Given this list of marker genes SNUPN, MAPT, GMPPB, MORC2, NOTCH2NLC, ABCD1, GNE, RILPL1, FKTN, COL13A1, AIFM1, MPZ, HARS1, SCYL1, SLC12A6, VWA1 (NCBI Gene Id 64856), AGRN, GDAP1, WARS1, DNM2, SLC5A6, IBA57, BSCL2 (BSCL2 lipid droplet biogenesis associated, seipin), HSPB8, DDHD2, VCP, EXTL3, PNPLA6, MT-ATP6, HINT1, SECISBP2, PMP22, SPG11, TRPV4, SPTLC2, VAMP1, GNB4, MATR3, TTN, PMP2, CHCHD10, JAG2, SARDH, MME, GYG1, GARS1, BICD2, HSPB1, TPM3, RAB7A, ANO5, NDRG1, LMNA, FLNC, GJB1, TDP1, FGD4, SORD, SPTAN1, SLC25A1, HSPB3, MTRFR (NCBI Gene Id 91574), ADSS1, DES, RTN2, MTMR14, HK1, MTTP, REEP1, SLC18A3, SBF1, MFN2, DYSF, MYO9A, EGR2, SMPX, SYT2, PNKP, COQ7, FBLN5, VHL, SNAP25, PLEC (plectin), KIF1A, NEFL, CHAT, TCAP, ATL1, DHTKD1, LRP12, SBF2, SLC5A7, CCND1, CPT1C, MYH7, PRX, GIPC1, EMILIN1, here is a description of the gene set: Human Gene Set: HP_DISTAL_LOWER_LIMB_MUSCLE_WEAKNESS Distal lower limb muscle weakness species: Homo sapiens Reduced strength of the distal musculature of the legs.